Given this list of marker genes CDK6, CDK4, CDKN2A, here is a description of the gene set: Missense and nonsense mutations in the CDKN2A gene that result in amino acid substitutions in p16INK4A or p16INK4A truncations, respectively, impairing its ability to bind to CDK4 and CDK6, interfere with p16INK4A-mediated induction of cellular senescence in response to oxidative stress.<br>Loss-of-function mutations in p16INK4A can also contribute to cancer by interfering with p16INK4A-mediated inhibition of NFKB signaling. part of: Evasion of Oxidative Stress Induced Senescence Due to p16INK4A Defects species: Homo sapiens Reactome Pathway: Evasion of Oxidative Stress Induced Senescence Due to Defective p16INK4A binding to CDK4 and CDK6